The following is a description of a gene set: species: Homo sapiens Human Gene Set: GSE3720_VD1_VS_VD2_GAMMADELTA_TCELL_DN Genes down-regulated in gamma delta T cells: Vd1 versus Vd2. from publication Kress E, Hedges JF, Jutila MA (PMID 16423401) The two major human gd T cell subsets, Vd1 and Vd2, display differences in tissue tropism and agonist responses, but we have little insight into global differences that may exist at the gene expression level. This is due to the small numbers of these cells that can be obtained from healthy donors, which limit comprehensive, comparative gene expression analyses. We established a culture method that expands Vd1 and Vd2 cells from the same PBL preparation to levels sufficient for sorting and microarray analysis. Although the subsets were expanded identically (anti-TCR mAb, plus IL-15), 392 and genes were identified, which were differentially expressed in the two subsets, from two donors, respectively. Approximately genes changed in both subsets following PMA/ionomycin treatment; about 50% of these genes were subset-specific. Both subsets responded to a crude LPS preparation, but only 6% of the responsive genes were the same. The differentially expressed genes were consistent with Vd2 cells being more inflammatory and Vd1 cells having more of a regulatory phenotype. Both subsets expressed transcripts encoding an array of innate and NK cell receptors, supporting the relationship of gd T cells to the innate immune system. Our results show that circulating Vd1 and Vd2 subsets in humans have considerable, inherent differences in gene expression following treatment with non-TCR agonists, supporting unique functional roles for these cells in vivo., and this is the list of marker genes: DNAI3, MRPS6, CSNK2B, IL4, PDE6H, SNX2, PTMS, CCN4, RGS10, CDK5R1, TMEM165, COTL1, CKS2, GNL3, EZH2, PDZK1, SLC22A17, KHDRBS3, GSTM1, SP6, LPP, ATP5MF, REPIN1, KLRG2, MTMR11, DHRS3, ATP5PF, MATK, GALNT9, OSGEPL1, LTB4R, LCLAT1 (NCBI Gene Id 253558), ZNF518B, NUCKS1, IL13, RCC2, ANG (NCBI Gene Id 283), TRPM6, DPH1, STMN1, ZNF23, SSMEM1, PEX1, REL, PTK2B, DOCK4, ENPP2 (NCBI Gene Id 5168), POU2AF1, CFB, TTC39C, SPCS1, SRGN, TIAM1, NPNT, SRSF7, LINC01973, GMDS, NEU3, PFKFB3, TOR1AIP2, PDCD1, PSD, CD300LB, RAD51B, LBH, AKR1A1, PPM1G, DMRTB1, ALDOC, NR4A2, GARIN3, MCM4, ARHGAP19, ADCY5, NOPCHAP1, TUBGCP2, RGS2, MRPL42, SAA1, RUFY3, FH (NCBI Gene Id 83748), C3, SRSF9, GPA33, VIPR2, HEY1, LCP2, MIF, CDC42EP5, PSMC2, BIRC5, TUBA8, UBL5, CD160, TMEM179B, GNGT2, PLXNC1, TMEM131L, TRIM59, RAMP1, ASNSD1, ATP9B, STX4, DRAM1, UCK2, NHP2, UMPS, ASCL2, RNF128, EGLN3, CSTB, GPRC5D, ATXN10, PHLDA1, TK1, TNFSF11, KIF20A, SLC30A3, MED31, AKT1S1, MTRES1, RGS1, PLEKHH2, PADI3, ANP32B, USP1, NANOS1, CDCA5 (NCBI Gene Id 256676), VDAC1, ADAM2, KDM2B, SPC24, KIF11, ATP5ME, B3GNT2, OTX2, TMEM38B, SCAF11, DBI, POMP, FAM43A, SCCPDH, POSTN, PDCD1LG2, IL1RN, BUB1, HSPA9, COPZ1, VCPKMT, MAT2A, CEP85, DPYSL3, CMSS1, MCM3, TATDN1, OXSR1, CAPG, MCCC2, PTPN11, HOXD13, EPHA4, VCP, UFSP1, CFAP54, HSBP1, STAMBPL1, ARID5B, LY6K, TTC33, SORBS3, BCL6B, CREG2, TNFSF8, FANCM, TACC3, CSTA, TIMM8B, MIX23, MAST2 (NCBI Gene Id 23139), FYTTD1, LARP7, UBE2L3, MTHFD1L, SLC36A4, PPP1R36, ECE1, CD83, DCLK1, VAMP5, BRD3, HIF1A, RILPL2, IKZF4, FBN2, HMCES, RPN1, SPOCK2, MEAF6, GNG2, PFKL